Given this list of marker genes ZNF565, ABCB9, THOC1-DT, BORCS8-MEF2B, TRAV6 (NCBI Gene Id 6956), SLC39A8, GFRA2, CHCHD6, PTPRS, ZNF107, AMACR, HPCAL1, SLC26A7, FAIM, PITPNM2-AS1, MIGA2, SOX13, LINC01629, ZNF626, RNU6-269P (RNA, U6 small nuclear 269, pseudogene), KLC2-AS2, RTF2, HLCS, SMTN, COMT, HECTD1, RNU7-182P, MIR4446, LENEP, OXR1, SH2D2A, FAM117A, GPAT4, RAB40B, NRXN3, NUDC, MYO1C, C2orf15, NDUFA10, RAB1B, SSB, GIPR, AGAP1, HMGN1, RSPRY1, RSAD2, TTC7A, MOK, SLC14A1, STRN4, RGMA, CLPTM1L, ASB1, PAG1 (NCBI Gene Id 55824), TYK2, BORCS8 (BLOC-1 related complex subunit 8), TARDBP, MTHFD2, BBIP1, HOTTIP, AGA (aspartylglucosaminidase), MYO10, LYL1, FOXP2, LINC01852 (long intergenic non-protein coding RNA 1852), DPM1, PSMG1, UROD, INPPL1, MBL1P, STX17, GFOD2, RN7SL448P, SLC43A2, RPL28, PRPF40B, TMEM238, DROSHA, RCC1, SYT16, GSDME, ASF1B, ICE1, SNTG2, CDC7, TENT5C-DT, AKAP1, MMACHC, DIP2A, WNK2, NME2, SELENOK, C19orf81, COL2A1, CACNA1D, ZNF331, HGS, RLIG1, STX18, IDO1, KCNJ13, GRPR (gastrin releasing peptide receptor), ITPKB, PPP1R10, BRWD1 (bromodomain and WD repeat domain containing 1), NEK6, KRTAP8-1, CIPC, SAMD4A, RFC1, GPATCH1, VTI1A, TTC28-AS1, RNA5SP451, IGF1R, SHOC2, DNAAF1, EXOSC8 (exosome component 8), ACE, DHRS7, ALKBH6, TRIM3, GCNT2 (NCBI Gene Id 880), LINC01610, SGTA, RELB, SLC46A2-AS1, ACTN4, TAF1C, DLG5-AS1, ENSG00000267698, ADAM15, CUX1, NFE2L3, TNFAIP8, HNRNPU, ABCC1, SRSF10, RBM22, ENSG00000271858, XRCC1, COQ8A, ZNF85, CYBRD1, PTCD3 (NCBI Gene Id 55037), LINC02931, PPP3CC, BRWD1-AS1, DNM1, MIR646, RNF145, CPVL, ZNF268, LINC00052, KAT7, UXS1, RNF187, OSTC, PABIR1, TMBIM1, THBS4, SETDB1, GTDC1, MZF1, TOR2A, RN7SL144P, ITGB1-DT, SEMA4D, CACNA2D2, UBBP3, IL6R, RAPGEF4, RN7SL260P, MIR9-1HG, CAMKMT, EPC2, TEX41, USP43, C11orf24, NXN (NCBI Gene Id 64359), SLC38A2, ASPHD1, SIDT1, PPP2CB, CIZ1, TRIM14, DIDO1, EFNA5, SVIP, SH3BP4, G3BP2, FAM83F, AGL, LAIR1, MIR3199-2, GUSBP5, CLSTN3, FBXO8, RPL7AP75, ENSG00000269954, MIR4760, TAB2, IGFLR1, GLRA1, IQCH, INSL6, NUDCD1, ANTKMT, MCRS1, NT5DC3, BRWD1P2, AGTPBP1, MYPOP, ALG5, TARS3, PIGC, RASGEF1C (RasGEF domain family member 1C), MFRP, ERAP1, TTI2, ANXA2R-AS1, GCK, GIMAP5, PSME3IP1, GNA11, CLXN, C16orf89, THSD1, IRAG2, EXO5, OSBPL9, PITPNB, ZNF696, KRIT1, SNHG3, ATXN7L1, LRRC75B, TAB3, RPL39P39, BICDL3P, R3HCC1L, PIWIL4, SLC27A1, SLC2A9, ATP13A1, ETNK1 (NCBI Gene Id 55500), TRAPPC12, MAK, C2orf92, NOTCH3, SPTAN1, PREPL, IGBP1P1, TMEM68, ATP8B3, GRAMD2B, ETNK1-DT, VSIG10, SLC25A37, ERI3, IFNLR1, AKAP11, HNRNPK, IGFBP2, GTF3A, MED24, HAVCR2, SRC, CCL4L2 (NCBI Gene Id 9560), TMF1 (NCBI Gene Id 7110), SYVN1, CMPK2, NSMF, CDK5RAP1, MBD3, ABCD3, MTHFSD, ITPR2, RPL10, LNCATV, NFKB1, DARS1, DNAH12 (dynein axonemal heavy chain 12), ZNF34, ERF, TMEM44-AS1, SNORD13, RFXANK, PPIC-AS1, HAPSTR1, POU2AF1, LINC02004, CREBRF, EXO5-DT, LAMB1, IFT27, FARP2, RNU6-626P, EMCN, TNRC6B, SPATA6, SLC23A2, MTCO1P23, TNRC6B-DT, RPL26L1-AS1, C11orf58, DOC2B, GABRA6, SGK1, CFAP221, MFN1, DYNC1I1, LINC01754, UBE2D3, ZBTB48, TMSB15B, TXNRD2, BCL6, MAP3K2-DT, STIM1, MAP3K2, MIR34AHG, GRK1, FKBP9P1, DSG1, ULK1, KIAA0319, LINC00567, ACSM3, LARS1, RBP5, RPL26L1, PLA2G4E-AS1, SLC6A1, ETV5, GIT1, NMNAT2, FCMR, SSPOP, AHNAK, DYNLRB2, LAIR2, XPO7, NF2, TMEM216, SLC1A2-AS2, TRANK1, ANKRD13D, PRR34, PRDM4, ADNP2, DNAJC6, PIGR, DAG1, GABRB2, OXR1-AS1, HCFC1R1, GPA33, TGS1, IRF1, GCKR, ATG4C, SPC24, ABCC5, INTS12, ENO3, FUT4, PHLDB2, SMARCA2, SLC39A3, EHD4, CENPBD2P, DMRTA2, DCLRE1B, SNRPF, ZNF146, INPP5F, AZGP1, CTNNA1 (catenin alpha 1), IL20, RN7SL282P, FCRLB, DDHD1 (NCBI Gene Id 80821), here is a description of the gene set: from publication Yevshin I, Sharipov R, Kolmykov S, Kondrakhin Y, Kolpakov F (PMID 30445619) Human Gene Set: EBNA1BP2_TARGET_GENES Genes containing one or more binding sites for (EBNA1BP2) in their promoter regions (TSS -1000,+100 bp) as identified by GTRD version 20.06 ChIP-seq harmonization. species: Homo sapiens